The following is a description of a gene set: species: Homo sapiens Reactome Pathway: Activation, myristolyation of BID and translocation to mitochondria part of: Intrinsic Pathway for Apoptosis BID may promote cell death by activating BAX and BAK while inactivating anti-apoptotic proteins. The engagement of cell surface receptors activates the caspase-8, a heterodimer, that cleaves BID in its amino terminal region. This particular event may act as a link between Extrinsic (caspase 8/10 dependent) and Intrinsic (Bcl-2 inhibitable) pathways although some evidences from mouse genetic experiments suggest the contrary. It has been suggested that the death signals from the extrinsic or death receptor pathway may get amplified by the mechanisms of intrinsic pathway and that this functional loop may be enabled by the molecules like tBID (truncated BID).<BR> Cleavage of BID to tBID can also be achieved by Granzyme B. The truncated protein is myristoylated and translocates to mitochondria., and this is the list of marker genes: GZMB, CASP8, BID, NMT1